The following is a description of a gene set: Mouse Gene Set: GOMF_HISTONE_H3K4_METHYLTRANSFERASE_ACTIVITY studied in species Mus musculus Catalysis of the reaction: S-adenosyl-L-methionine + histone H3 L-lysine (position 4) = S-adenosyl-L-homocysteine + histone H3 N6-methyl-L-lysine (position 4). This reaction is the addition of up to three methyl groups to the lysine residue at position 4 of the histone H3 protein., and this is the list of marker genes: Setd7, Setd3, Kmt2d, Smyd1, Smyd2, Setbp1, Setd1a, Wdr5, Setd1b, Kmt2c, Ash1l, Nsd3, Ash2l, Setd4, Setmar, Kmt2b, Prdm9, Smyd3 (SET and MYND domain containing 3), Kmt2e, Kmt2a